The following is a description of a gene set: Abnormal pulmonary interstitial morphology Abnormality of the lung parenchyma extending to the pulmonary interstitium and leading to diffuse pulmonary fibrosis. studied in species Homo sapiens Human Gene Set: HP_ABNORMAL_PULMONARY_INTERSTITIAL_MORPHOLOGY, and this is the list of marker genes: DNAI1, FASLG, RTEL1, TOM1, CASP10, PSMC3IP, UNC119, CCNO, DNAAF11, COPA, FAM111B, HLA-DPA1, PIK3CG, ABCA3, NUP107, STK36, DNAAF2, BNC1, MSH4, DNAJB13, NAF1, BTNL2 (butyrophilin like 2), NEK10, NME5, GBA1, DNAH5, NRAS, DOCK2, FARSB, ASAH1, HPS1, ITGA3, FOXP3, FOXJ1 (forkhead box J1), RSPH4A, CFAP74, NHP2, RCBTB1, CCR6, IRF5, TERT, CTLA4, IL1RN, BTK, CCDC39, FAM13A, SFTPB, CCN2, OFD1, CTC1, STAT3 (NCBI Gene Id 6774), HLA-DRB1, NME8, PLCG2, DNAH9, DNAL1, NSMCE3, EHHADH, FARSA, BACH2, RNF168, SFTPC, RPA1, DNAAF3, THOC2, ATP11A (ATPase phospholipid transporting 11A), CFAP221, STAT5B, PRTN3, AP3B1, ZCCHC8, STXBP2, NDUFAF6 (NADH:ubiquinone oxidoreductase complex assembly factor 6), PLEC, NOP10, DRC1, CAV1, SLC7A7, PARN (NCBI Gene Id 5073), IL2RA, COL3A1, PTPN22, TP53, LRRC56, PAK2, HLA-DPB1, NR5A1 (nuclear receptor subfamily 5 group A member 1), RPGR, SLC34A1, CSF2RB, FSHR, DNAH11, CFAP298, SMPD1, NKX2-1, DNAAF6, HCK (HCK proto-oncogene, Src family tyrosine kinase), NHLRC2, DKC1, MUC5B, ODAD3, HPS6 (NCBI Gene Id 95477), MAP2K1, RSPH9, DPP9, CSF2RA, ODAD4, KIAA0319L, HLA-B, BMPR2, POT1, SPEF2 (NCBI Gene Id 80192), ZSWIM7, BMP15, TERC, RSPH1, SCARB2, SFTPA1, TINF2, ODAD2, MARS1, RSPH3, ODAD1, CFAP300, RAC2, IL2RB, DSP, DNAH1, AP3D1, CCDC40, AGR2, ZMYND10, MCIDAS, NPC2, DNAI2, CYBC1, SPIDR, RAG1, SLC34A2, HYDIN, DNAJB4, DNAAF1 (NCBI Gene Id 123872), BRAF, MRPS22, ZNFX1, SP110, GATM, FAS (NCBI Gene Id 355), DNAAF4, SFTPA2, STING1, TTC12, POLR3H, SPAG1, DNAAF5, HPS4, EIF2AK4, STN1, GAS2L2